The following is a description of a gene set: Genes up-regulated in CD4 Th17 T cells: enriched versus negative. species: Homo sapiens Human Gene Set: GSE32901_TH17_EMRICHED_VS_TH17_NEG_CD4_TCELL_UP from publication Zhang W, Ferguson J, Ng SM, Hui K, Goh G, Lin A, Esplugues E, Flavell RA, Abraham C, Zhao H, Cho JH (PMID 22715389) In this study, we examined differential gene expression in naïve human CD4+ T cells, as well as in effector Th1, Th17-negative and Th17-enriched CD4- T cell subsets. We observed a marked enrichment for increased gene expression in effector CD4+ T cells compared to naive CD4+ among immune-mediated disease oci genes. Within effector T cells, expression of disease-associated genes was increased in Th17-enriched compared to Th17-negative cells. We used microarray to examine the gene expresssion profile and level of human naïve, Th1 and effector T cell subsets., and this is the list of marker genes: PRSS51, NXF3, KCNMB3, DRD5, MIR187, EIF2B4, CD302, NDUFA12, SBK2, GRM2, KIF26A, TMEM220, CYP26B1, OSBPL5, CLEC4G, RPS13, GHSR, DNAJC22, FBXO33, HAPLN3, PKD2, HSD3B1, CYP4B1, SDSL, TMEM200B, NXT1, NXPE3, TSC22D3, RPL8, CXXC4, MAGEL2, AXIN2, HSD11B1, TMEM26, ZFP57, MYOZ1, ACTRT1, UGGT2, GPR173, DNAJC19, VEGFD, PLA2G12A, AIPL1, UPP1 (uridine phosphorylase 1), EXOC8, SLC38A8, ETV2, UNC13B, TGFBI, TACR2, MSRB2, SVIP, SEC61G, NOM1, MYH8, GPR137B, HSD17B7, DYNLT5, GLS2, LPO, SLC9A3, MIR125A, NUDT8 (nudix hydrolase 8), PADI6, EPM2AIP1, MAP3K21, VTN, RHOV, FOXP2, H2AB1, LIPT1, SCN3B, MIR150, LRRC56, CBLN3, HCST (hematopoietic cell signal transducer), CRCT1, GNA14, DOK2, CNP, CNDP1, CCDC73, RPS8, MIR495, ACE, TRIB2, TENT5C, CNMD, UFSP1, TMEM121B, SH2B2, CBX8 (NCBI Gene Id 63441), PANX2, TLR3, PRRG3, KYAT3, AMOT, METTL13, FGF17, CCS, SLC5A3, SLC17A8, CNKSR2, L2HGDH, FAM168B, SLC26A3, MIR485, TSSC4, LMLN, ADRB2, DNAJB2, BAHCC1, TRMT12, FAM83E, RHOU (ras homolog family member U), SLC66A2, WASHC3, C16orf54, OPRPN, TRA2A (transformer 2 alpha homolog), OTP, EIF3K, MIR16-1, KLHL21, GSTP1, ACOT6, ARFRP1, GHR